The following is a description of a gene set: studied in species Mus musculus Any process that stops, prevents, or reduces the frequency, rate or extent of cardiac muscle cell proliferation. Mouse Gene Set: GOBP_NEGATIVE_REGULATION_OF_CARDIAC_MUSCLE_CELL_PROLIFERATION, and this is the list of marker genes: Mapk11, Nog, Sav1, Kcnk2, Jarid2, Tbx5, Apc, Cited2, Trp73, Rbp4, Tgfbr2, Vgll4, Mir1a-2, Hdac2, Gja1 (NCBI Gene Id 14609), Pten (NCBI Gene Id 70161), Cxadr (coxsackie virus and adenovirus receptor)